The following is a description of a gene set: Genes having at least one occurrence of the motif NNNGNRRGNACANNGTGTTCTNNNNNN in the regions spanning 4 kb centered on their transcription starting sites. This matches the AR transcription factor binding site V$AR_02 (v7.4 TRANSFAC). Human Gene Set: AR_02 studied in species Homo sapiens, and this is the list of marker genes: SREK1, TRIM63, RBM24, LOX, PPP1CC, SCNN1A, NCDN, WT1-AS, TNS2, SLC7A8, CIART, ZMYND8, LARP4, RELCH, PLAG1, ADCY6, PHC2, EPHA7, IKZF2, SMOX, IL27, DNAJB4, TIMM8A, SLAIN1, CFAP65, CD52, SPTBN1, IP6K2, BCL6, GOT2, TXNIP, FIGN, LINC00472, ADNP (NCBI Gene Id 256440), KCNJ1, PHF21A, KCTD4, FGF17, RWDD1, CHCHD7